Given this list of marker genes SIX1, SIX4, GDNF, GATA3, FGF2, MMRN2, VEGFA, PIK3CD, EGF, here is a description of the gene set: Human Gene Set: GOBP_POSITIVE_REGULATION_OF_EPITHELIAL_TUBE_FORMATION studied in species Homo sapiens Any process that activates or increases the frequency, rate or extent of epithelial tube formation.